The following is a description of a gene set: studied in species Homo sapiens Human Gene Set: GOBP_NEGATIVE_REGULATION_OF_ENDOTHELIAL_CELL_APOPTOTIC_PROCESS Any process that stops, prevents or reduces the frequency, rate or extent of endothelial cell apoptotic process., and this is the list of marker genes: ANGPTL4, PDPK1, GAS6, SCG2, MIR30E, KRIT1, GATA2, ABL1, SERPINE1 (serpin family E member 1), IL10, MIR590, TERT, MAPK7 (mitogen-activated protein kinase 7), GATA3, CDH5 (cadherin 5), FGA, BRAF, ID1, FGB (fibrinogen beta chain), IL13, ICAM1, IL4, SEMA5A (semaphorin 5A), MIR126, TEK, IL11, NDNF, PAK4, FUT1, ITGB3, MIR30B, MIR495, TNFAIP3, TNIP2, KDR, FGG, ANGPT1, RAMP2, NFE2L2